The following is a description of a gene set: electronically inferred by orthology from the curated human pathway studied in species Mus musculus Reactome Pathway: Glucagon-type ligand receptors part of: Class B/2 (Secretin family receptors) This event has been computationally inferred from an event that has been demonstrated in another species.<p>The inference is based on the homology mapping from PANTHER. Briefly, reactions for which all involved PhysicalEntities (in input, output and catalyst) have a mapped orthologue/paralogue (for complexes at least 75% of components must have a mapping) are inferred to the other species., and this is the list of marker genes: Vip, Gng5, Gng8, Gng10, Adcyap1, Vipr1, Gng7, Gcgr, Gngt1, Gnb5, Gngt2, Gip (NCBI Gene Id 14607), Gng11, Sct, Ghrhr, Gnb3, Sctr, Gipr, Gcg, Ghrh, Glp2r, Gng3, Glp1r, Vipr2, Gng4, Gnb2